Given this list of marker genes CCDC88B, LDB1, ACLY, TMIE, PTMS, VRK1, CPSF3, SLC22A5, WNT10B, ZDHHC8, TXN2 (thioredoxin 2), SDR39U1, PLPPR1, WDR3, NHERF4, PLEKHH1, ELK1, CLDN7, API5, C6orf132, ATG2A, KIAA1217, EOMES, DYNC2I1, DHX32, FSCN1, PSPH, CDKAL1, DTX4, CNIH1 (cornichon family member 1), SEMA5B, POMP (proteasome maturation protein), CSAD, LRRC40, DLG3, SNX19, NME6 (NME/NM23 nucleoside diphosphate kinase 6), GPATCH3, NUSAP1, TBC1D13, DRC1, PNMA8B, ZMYND8, NDUFV2, GET4, KLHDC10, C2orf76, PDHA2, PEF1, RINT1, BTBD1, MYO9B, QSOX2, SETDB2, TAF4B, RAB39B, NBN, MLEC, SPATA2, CRELD2, BLOC1S5, ARID1A, GPX3, MOV10, GFUS, TRIO, HK2, UTS2R, HTR2B, LAS1L, SCAF4, ZNF2, MKRN2, SKIC8, RBM10, STN1, FRS2, SLC4A1AP, POM121L12, STK40, SLC30A6, PHACTR4, SETDB1, ZBTB24, FBXO38, ADAMTS16, ISY1, MIB2, MKNK2, EXOSC1, ACSL5, POC5, TSC2, JADE3, CPOX, ARFIP1, SLC26A11, NDUFV1, PRR14, PCNT, BUD31, RRS1, MAP1S, HDC, TAPT1, SEC61A2, ARHGEF4, PRKAB2, PHPT1, NOP16, RNF44, HSPA4L, ZMPSTE24 (zinc metallopeptidase STE24), TFAM, RNF24, NXPH2, ARL5B, PPP5C, CGAS, EIF4A1, LCMT2, CCNA2, CSTPP1, TRIR, BANK1, SPPL2B, HIRA, DESI2, CLSTN2, ENY2, NDUFS3, ANKRD40, NT5DC3, TRAPPC5, COPS3, C12orf56, ZNF184, FBXO46, BLNK, AK1, SEC23B, MRPL2, GRIA2, DLEU7, WFS1, ARRDC2, COLQ, HOOK2, RGS19, CIART, COX19, FBXO42, ADI1, DRG1, CDK2, NAT8, ZPR1, CERS6, CRYL1, STRAP, METTL13, PEX11A, CPQ, MYO19 (myosin XIX), HDAC1, ANKDD1B, CAPSL, SUN2, PPIP5K1, NFKBIE, NOTUM, FAM120C, LTV1, KCNAB3, GNL3, NDST1, TELO2, CARMIL2, TP53INP2, NECAP2, ZNF483, RSPH3, MPC1, MAGED1, THEM6, NMT1, POLR2E, FAM20A, NISCH, F2, IL6ST, NELFCD, OPTN, HDAC5, TERF2, WDR54, RNMT, CNIH3, HRH3, CCND2, here is a description of the gene set: species: Homo sapiens Human Gene Set: GSE14308_TH2_VS_INDUCED_TREG_DN Multipotential naïve CD4+ T cells differentiate into distinct lineages including T helper 1 (Th1), Th2, Th17, and inducible T regulatory (iTreg) cells. The remarkable diversity of CD4+ T cells begs the question whether the observed changes reflect terminal differentiation with heritable epigenetic modifications or plasticity in T cell responses. We generated genome-wide histone H3 lysine 4 (H3K4) and lysine 27 (H3K27) trimethylation maps in naïve, Th1, Th2, Th17, iTreg, and natural (n)Treg cells. We found that although modifications of signature cytokine genes (Ifng, Il4, and Il17) partially conform to the expectation of lineage commitment, critical transcription factors such as Tbx21 exhibit a broad spectrum of epigenetic states, consistent with our demonstration of T-bet and IFN-gamma induction in nTreg cells. Our data suggest an epigenetic mechanism underlying the specificity and plasticity of effector and regulatory T cells and also provide a framework for understanding complexity of CD4+ T helper cell differentiation. Genes down-regulated in comparison of Th2 cells versus induced regulatory T cell (Treg). from publication Wei G, Wei L, Zhu J, Zang C, Hu-Li J, Yao Z, Cui K, Kanno Y, Roh TY, Watford WT, Schones DE, Peng W, Sun HW, Paul WE, O'Shea JJ, Zhao K (PMID 19144320)